The following is a description of a gene set: Inhibition of GNAQ-regulated signaling in uveal melanoma species: Homo sapiens Human Gene Set: WP_INHIBITION_OF_GNAQREGULATED_SIGNALING_IN_UVEAL_MELANOMA, and this is the list of marker genes: TEAD4, PIK3R1, PIK3R3, TEAD3, MAPK1, PKN2, MOB1A, PLCB4, AKT1, PTK2, LATS2, PKN3, PIK3CD, PIK3CA, AKT3, PLCB2, TEAD2, PIK3R2, AKT2, TEAD1, MTOR, PLCB1, TRIO, PIK3CB, RHOA, GNAQ, TSC1, TSC2, YAP1, PLCB3, LATS1, ROCK1, PKN1